The following is a description of a gene set: Genes positively differentially expressed in cell type: eTAC (extrathymic Aire-expressing cell) upon treatment with cytokine: IFN-γ in mouse lymph nodes in vivo. from publication Cui A, Huang T, Li S, Ma A, Pérez JL, Sander C, Keskin DB, Wu CJ, Fraenkel E, Hacohen N (PMID 38057668) studied in species Mus musculus Mouse Gene Set: CUI_ETAC_IFNG_RESPONSE_UP Cytokines mediate cell-cell communication in the immune system and represent important therapeutic targets. A myriad of studies have highlighted their central role in immune function, yet we lack a global view of the cellular responses of each immune cell type to each cytokine. To address this gap, the authors created the Immune Dictionary, a compendium of single-cell transcriptomic profiles of more than 17 immune cell types in response to each of 86 cytokines (>1,400 cytokine-cell type combinations) in mouse lymph nodes in vivo. A cytokine-centric view of the dictionary revealed that most cytokines induce highly cell-type-specific responses. For example, the inflammatory cytokine interleukin-1β induces distinct gene programmes in almost every cell type. A cell-type-centric view of the dictionary identified more than 66 cytokine-driven cellular polarization states across immune cell types, including previously uncharacterized states such as an interleukin-18-induced polyfunctional natural killer cell state., and this is the list of marker genes: Cxcl9, Gbp2, Gbp4 (guanylate binding protein 4), Serpina3f, Gbp5, Stat1, Iigp1, Slamf8 (NCBI Gene Id 74748), Gbp7, Igtp, Oas3